The following is a description of a gene set: studied in species Homo sapiens Transport of substances into, out of or within a peroxisome, a small, membrane-bounded organelle that uses dioxygen (O2) to oxidize organic molecules. Human Gene Set: GOBP_PEROXISOMAL_TRANSPORT, and this is the list of marker genes: PEX2, PEX6, PEX7, PEX14 (peroxisomal biogenesis factor 14), TRIM37, PEX5L, PEX10, PEX16, PEX1, ABCD2, PEX3, RAB8B, PEX19 (peroxisomal biogenesis factor 19), ABCD1, PEX26, PEX13, PEX12, ABCD4, USP9X, PEX5, LONP2, ABCD3